The following is a description of a gene set: Mouse Gene Set: GOCC_TRAPPIII_PROTEIN_COMPLEX species: Mus musculus A complex that functions in anterograde transport at the Golgi and also regulates autophagy. In yeast it includes at least the following subunits: Bet3 (as homodimer), Bet5, Trs20, Trs23, Trs31, Trs33, Trs85. TRAPPIII may include further, as yet undescribed, proteins., and this is the list of marker genes: Trappc6a, Trappc13, Trappc11, Trappc1, Trappc4, Trappc8, Trappc3, Trappc2, Trappc2l, Trappc12, Trappc5